The following is a description of a gene set: Human Gene Set: chr2p25 species: Homo sapiens, and this is the list of marker genes: PIK3CDP1, ENSG00000226506, TRAPPC12, ROCK2, ENSG00000294395, MIR548S, PXDN, TMEM18, NRIR, RNU6-649P, RNF144A, TAF1B, ENSG00000287126 (NCBI Gene Id 124907726), LINC00487, LINC01249, ALLC, LPIN1, CMPK2, YWHAQ, ODC1-DT, ENSG00000303569, LINC01874, ENSG00000284452, LINC03037, ENSG00000206647, KCNF1, ACP1, LINC01871, ENSG00000287119, ITGB1BP1, MBOAT2, NOL10, SH3YL1, ADAM17, HPCAL1, KLF11, LINC01248, RNU7-176P, LINC01810, MYT1L-AS1 (NCBI Gene Id 730811), MIR3681HG, CDK8P1, CPSF3, LINC01115, ENSG00000206898, RNU6-1081P, NPM1P48, LINC01247, GREB1, ASAP2, ENSG00000285569, E2F6, LINC01250, LINC00570, TRAPPC12-AS1, MIR4429, LINC01865, TPO, DCDC2C, RSAD2, ID2, RN7SL674P, RNASEH1, CYS1, MYT1L, MIR4262, ENSG00000287305, ADI1, RNU2-13P, KIDINS220, EIPR1-IT1, LINC01939, RPL6P4, MIR7515HG, RNASEH1-DT, MIR7515, ENSG00000228496, SNORA80B, ENSG00000229727, ID2-AS1, CIMIP5 (NCBI Gene Id 130813), MIR4261, EIPR1, RRM2, MIR7158, RNU4-73P, SNRPEP5, ODC1, RN7SL832P, HMGB1P25, TMEM18-DT, ALKAL2, RPS7, EIF1P7, LINC01824, COLEC11, RNU7-138P, ENSG00000233633 (novel transcript), ENSG00000237720, FAM110C, ATP6V1C2 (NCBI Gene Id 245973), SNTG2-AS1, ENSG00000236106, ENSG00000231083, GAPDHP48, LINC01875, TMSB4XP2, ENSG00000235779, ENSG00000303501 (NCBI Gene Id 124905969), ENSG00000285872, LINC00299, ENSG00000240687, RPL30P3, NTSR2, LINC01304, SNTG2, LINC01954, RN7SKP112, SOX11, LINC02973, SILC1, PDIA6, AIDAP1, RNU6ATAC37P, GRASLND (NCBI Gene Id 386597), RNA5SP84, SLC66A3, IAH1, GRHL1, PPIAP60, RN7SL66P